The following is a description of a gene set: from publication Chen Y, Wang X (PMID 31504780) Human Gene Set: MIR190A_5P Genes predicted to be targets of miRBase v22 microRNA hsa-miR-190a-5p in miRDB v6.0 with MirTarget v4 prediction scores > 80 (high confidence targets). studied in species Homo sapiens, and this is the list of marker genes: RCOR1, CHD7, MEGF10, ANKRD34A, MMAA, YTHDF3, SHANK2, EPC2, ZNF665, WSB1, NBEA (NCBI Gene Id 55091), CAMK1D, PAX6, RBAK, DMXL1, ZSCAN31, IKZF2, BACH2, CWC27, TRIM33, KLF15, MED4, CDIN1, PTHLH, AZIN1, ORC4, DAG1, DMD, HECA, TRPS1, FBXO22, STT3A, PALS2, CLOCK, PAX3, TRIM55, VWC2, ZBTB41, WDR44, STK38L (NCBI Gene Id 23012), FNDC3A (NCBI Gene Id 22862), NHLRC2, PSMA8, ZNF529, SMC6, CFLAR, MUC17 (NCBI Gene Id 402576), PHF20L1, LPCAT2, XRN1, FGF14, SEC23A, TOMM5, PHLPP1, OPA3, TNRC6A, MB21D2, CPOX, TNRC6C, GPHN, ZNF280D, TBC1D14, ADGRA1, OSBPL6 (NCBI Gene Id 84615), TRIM36, TAPBP, KCNK9, ARPC5 (actin related protein 2/3 complex subunit 5), ASAP2, ZDHHC15, CSN2, CEBPA, STK35, TANK, CELF4, XPO1, ROCK1, CSRNP3, SAMD4A, IL2, CDKN1B, DENND5B, TAS2R14, NBPF12, MRS2 (NCBI Gene Id 63855), BCL11A, KCNB1, KCNQ5, CAT, TMEM161B, KCNA4, NEUROD1, ERG, ADGRE3, SEC14L1, NLGN1, TNRC6B, TP53INP1, ANGPTL1, CROT, SPC25 (NCBI Gene Id 57405), MYO5A, DHRS12, ZNF585A, NOLC1, SYNJ1, MYCBP2, DEPDC5, TCF4, LMBRD2, RBL2, DOCK9